The following is a description of a gene set: studied in species Homo sapiens IL-10 or IL-6 stimulation of control 129xC57BL/6 murine bone marrow derived macrophages in the presence of LPS. We used microarrays to detail the global programme of gene expression changes in response to IL-6 or IL-10 stimulation in the presence of lipopolysaccharide. BMDMs were isolated from control, IL-6-/-, and IL-10-/- mice on a 129XBL/6 mixed background mice and differentiated in the presence of CSF-1 for 6-7 days. Cells were scraped and plated in 6 well plates at 2x10e6/well. Cells were washed with complete DMEM and rested for 1-2 hr before stimulation with combinations of IL-10 (10 ng/ml), IL-6 (2 ng/ml) or LPS (100 ng/ml) for 45 min or 180 mins. Complete biological replicates were performed. Genes down-regulated in bone marrow-derived macrophage (180 min): LPS versus IL10 and LPS. from publication El Kasmi KC, Holst J, Coffre M, Mielke L, de Pauw A, Lhocine N, Smith AM, Rutschman R, Kaushal D, Shen Y, Suda T, Donnelly RP, Myers MG Jr, Alexander W, Vignali DA, Watowich SS, Ernst M, Hilton DJ, Murray PJ (PMID 17114459) Human Gene Set: GSE5589_LPS_VS_LPS_AND_IL10_STIM_MACROPHAGE_180MIN_DN, and this is the list of marker genes: SH2D1B, TTC39B, MEGF9, ABI3, HSDL2, KRBA1, SEPTIN9, PARP8, NAA50, NFYC, ETFB, CAMSAP3, LRRC20, CLEC10A, CLCN4, LCP2, ANGPTL3, GLIS3, HNRNPR, TFPI2 (tissue factor pathway inhibitor 2), SCOC, ADAM22, DENND2C, RAP1B, MYO10, BST1, ATP5F1A, NDUFC2, ARF1, HEBP1, LRRC39 (NCBI Gene Id 127495), TMEM35A, SPAG1, ECI2, PKP2, ATP6V0A1, ABHD12, CD82, DAD1, TCERG1, SLCO2B1, PLXDC2, IL17RD, BCAR3, FRK, RALGDS, TGFB1, TRMT11, MTBP, IDE, ITGAV, RAB20, HMOX1, GET1, JPT1, P2RY14, SNHG3, SRSF1, UBE2L6, HGSNAT (NCBI Gene Id 8119), RRP1B, MYO1E, SDAD1, PLOD1, GARRE1, JAM2, ABCB1, SFPQ, RGL1, SH3KBP1, RAD51C (RAD51 paralog C), SGK1, CTNNB1, CD47, SIRPB1, TMEM176A, NFKBIA, STC2, C19orf12, TSPAN33, TMEM41A, NOP2, COL4A1, NFKBIE, MED7, HADHA, PCBP1, SRSF2, RPS11, PLA2G7, ADPGK, SORT1, ASPA, SLC25A51, PLIN5, MMD, NRM, ANO6, ACAA2, CLNS1A, KCNMB4, LRP1, PEX5L, MAPKAPK2, CAV2, NUFIP1, MRPL52, PGLS, NAP1L1, STRN4, IL10 (NCBI Gene Id 3586), DNAJA3, ERMP1, ABHD17C, ANGPTL4, DUSP9, ECH1, LMCD1, MMGT1, ELOVL5 (ELOVL fatty acid elongase 5), MICAL2, SEMA6D (NCBI Gene Id 80031), OXSR1, ARF3, PITPNM2, DMXL2, SLC9A6, RBIS, NIPA2, SLC12A7, RELT, COX20, NRCAM, SREBF1 (sterol regulatory element binding transcription factor 1), ADTRP, APOE, CAMK2D, SPTB (spectrin beta, erythrocytic), TOMM20, ADGRL2, NAPSA, SAMD4A, NEDD9 (NCBI Gene Id 4739), RNPC3, ZNF608, NKD2, PTGER4, SNORD123, AXL, CMPK1, MYBL1, NAALADL2 (NCBI Gene Id 254827), MAP2K3, EMP1, CLEC4A, RBMX, MGAT4A, BLTP3B, FCGR1A, COL4A2, GNB1, DNAJC19, TXN, EPOR, CLEC4E, ETFA, LPCAT3, MFSD1, CD36, ABHD3 (abhydrolase domain containing 3, phospholipase), LIMS2, GTF2A2, SNX9, CXCL14, HNRNPM, CAV1 (caveolin 1), GLRA4, TRA2A, XYLB, B4GALNT1, CDC42EP2, STK24, SERPINB6, RUNX2, SRSF6, HPF1, DIP2C, DHX29, NR1H3, UTP6, SYNE2, AKR1B15, HILPDA, TSPYL4, GABARAP, SLC39A10, KITLG, RASGRP4, AEBP2, MRPS18B